The following is a description of a gene set: Human Gene Set: REACTOME_MITOPHAGY studied in species Homo sapiens Mitophagy, and this is the list of marker genes: TOMM70, RPS27A, UBE2L3, PRKN, CSNK2A1, MFN2, TOMM40, CSNK2A2, ATG5 (NCBI Gene Id 9474), UBE2V1, OPTN, MFN1, TOMM6, UBE2D2, MAP1LC3B, ULK1, VDAC2, TOMM7, FUNDC1, UBC, ATG12, TOMM20, SQSTM1, UBE2N, UBA52, VDAC1, VDAC3, MAP1LC3A, UBE2D3, CSNK2B, MTERF3, ATG9A, TOMM5, TBK1, PGAM5, UBB, PINK1, SRC, TOMM22